The following is a description of a gene set: c-myc is a well-known proto-oncogene encoding for a transcription factor that needs to be tightly regulated in order to preserve cell homeostasis. The Promyelocytic Leukaemia gene product PML plays an important role in cell growth and survival, and resides in discrete subnuclear structures called Nuclear Bodies (NB). We performed comparative analysis of the expression of 40 Myc target genes and of Myc binding to their regulatory regions both in wild-type and PML knockout cells. We demonstrate that if PML is absent, despite Myc binding to the DNA regulatory sequences is unchanged, the expression profile of several Myc target genes is altered. PML is largely involved in gene regulation, via recruitment of several transcription factors and cofactors to the NB. Consistently, we show that Myc partially localizes to the NB and physically interacts with PML, and that this localization depends on Myc expression levels. As deregulation occurs to both activated and repressed Myc target genes, we propose that PML influences Myc transcriptional activity through a mechanism that involves the control of Myc post-translational modifications. studied in species Mus musculus Genes down-regulated in MEF cells (embryonic fibroblasts) after knockout of PML and whose promoters were bound by MYC. from publication Cairo S, De Falco F, Pizzo M, Salomoni P, Pandolfi PP, Meroni G (PMID 15735755) Human Gene Set: CAIRO_PML_TARGETS_BOUND_BY_MYC_DN, and this is the list of marker genes: CDKN2B, HSPA1B, CDKN1A, PDGFRB, CDKN2A, CAV1, CDKN1B, BCAT2, ADM, ERBB2, CCND1, IRF9, TERT